Given this list of marker genes Hoxd8, E2f3, Notch1, Zfp715, Smad3, Atf6, Men1 (multiple endocrine neoplasia 1), Esr1, Sox1, Tlx2, Gfi1b, Meis1, Nfix, Meox2, Zfp982, Gcm1, Mesp1, Klf1, Batf, Irf2, Zfp131, Myb, Rhox5, Pou4f1, Irx4, Cdx4, Egr3, Onecut1, Six3, Cdc5lrt10, Pdx1, Mga, Foxo4, Tcf3, Lmx1b, Hoxa13, Hoxd13, Fosb, Cdc5lrt5, Neurog3, Glis1, Myt1l, Srebf1, Sox9, Atf1, Foxk2, E2f4, Myc, Gabpa, Dmtf1, Yy2 (NCBI Gene Id 100073351), Nkx2-6, Gsx1, Sohlh1, Tfdp1, Pou1f1, Cdc5lrt6, Cdc5lrt1, Mef2d, Mafg, Isl1, Stat5a, Sox30 (NCBI Gene Id 278440), Creb3l4, Nfat5, Brca1, Zfp175, Onecut3, Stat3, Pou5f1, Sox14, Rhox6, Ebf3, Nr2e1, Smad2, Ets1, Zic2, Ascl2, Pou4f2, Tbx20, Nfib, Zfp384, Dlx5, Tfeb, Sry, Cebpe, Mlxipl, Bmyc, Nr1h2, Scx (NCBI Gene Id 20289), Mecom, Elf3, Hoxb9, Jun, Ppara, Nfe2l1, Nkx2-5, Ebf1, Neurod6, Nfatc1, Rhox4f, Zscan21, Dmrt1, Mef2b, Lmx1a, Sohlh2, Nkx6-3, Nfatc2, Irx6 (Iroquois homeobox 6), Hsf2, Prrx2, Sox18, Bhlha15, Tbx3, Meox1, Sox2, Atf5, Esrrb, Lhx4, Nr2e3, Spic, Sox15, Zfp580, Meis2, Zfp758, Atmin, Carf, Rfx2, Pax9, Hnf4g, Hoxc4, Myf6, Grhl2, Cdc5lrt9, Ncoa3, Lhx2, Hoxa7, Klf7, Hivep2, Stat4, Plag1, Creb3, Rxrb, Six5, Rfx5, Rhox7a, Lef1, Tfcp2 (transcription factor CP2), Otx2, Msx1, Pax6, Atf2, Nrf1, Zfp819, Notch2, Sox10, Creb5, Klf4, Fev, Nhlh1, Rbpj, Csrnp2, Tfec, Hoxb2, Arnt2, Tfap2d, Nrl, Jund, E2f1, Mkx, Ar, Foxd2, Irf3, Nr3c1, Crebrf, Rhox4b, Nfyc, Rhox2f, Elf4, Mybl1, Tfap2e, Cdc5lrt7, Sox7 (NCBI Gene Id 20680), Usf1, Rhox9, Ascl5, Foxj1, Zfp639, Klf15, Grhl3 (NCBI Gene Id 230824), Rhox3g, Zfp750, Sp1, Pou3f2 (NCBI Gene Id 77364), Foxf1, Cebpg, Hsf5, Rhox4c, Zfp143, Sox3, Rhox3c, Pgr, Foxa1, Neurod1, Yy1, Mef2a, Gzf1, Fosl1, Dlx3, Nkx2-1 (NCBI Gene Id 21869), Zscan2, Usf3, Nr4a3, Figla, Mef2c, Klf6, E4f1, Nr1i3, Grhl1 (grainyhead like transcription factor 1), Rbpjl, Rhox3a, Barhl2, Rorb, Zfat, Usf2, Hhex, Foxi1, Fos, Zfp930, Foxc1, Rhox4a, Mzf1, Zfp677, Irf5, Tfap4, Foxd1, Dlx2, Irf6 (NCBI Gene Id 98477), Trp53, Mesp2, Hoxb1, Egr4, Ptf1a, Barhl1, Gm14434, Cebpd, Rhox4g, Hoxb7, Tfcp2l1, Sp7, Rel, Myod1, Tfap2c, Phox2b, Hoxa9, Tead4, Cdc5lrt4, Tcf12, Mybl2, Sox11, Creb1, Ebf2, Elf1, Erg (ETS transcription factor), Tcf15, Rhox2h, Mtf1, Fezf2, Litaf, Gli2, Hnf1a, Hif1a, Zeb2, Nr1i2, Crx, Foxo3, Hoxb5, Nkrf, Plagl2 (NCBI Gene Id 99408), Foxj3, Junb, Tbx21, Zfp292, Fosl2, Atoh1, Foxa2, Dbp, Pparg, Rhox2c, Pitx1, Meis3 (Meis homeobox 3), Gata2, Irx3 (Iroquois related homeobox 3), Pax8, Foxc2, Spib, Hoxd3, Foxf2 (forkhead box F2), Zbed4, Plscr2, Tfap2a, Tcf7l2, Rfx4, Nobox, Nkx2-9, Pax1, Elk4, Nr6a1, Zfp341, Gata4 (NCBI Gene Id 14463), Klf13, Mitf, Rhox1, Mafa, Smad1, Prdm2, Hoxb3, Hoxa1, Lhx3, Nr1h3, Myf5, Fli1, Rhox4e, Ebf4, Cdkn2a (NCBI Gene Id 18560), Etv2, Arx, Stat5b, Glis3, Foxp3, Irf4, Hlf, Csrnp1, Zbtb17, Smad4, Nfya, Cebpa, Prdm16, Twist1, Dmrt2, Sox21, Ddit3, Hoxc10, Rfxank, Cdc5l, Nfatc3, Notch4, Pitx2 (NCBI Gene Id 338526), Alx4, Hsf1, Tfap2b, Onecut2, Irf1, Zic3, Rhox3f, Myt1, Nanog, Nr5a2, Phox2a, Elf5, Osr2, Rfx6, Glis2, Heyl, Mafb, Etv4, Rhox2g, Bsx, Etv1, Nhlh2, Ikzf3, Ubp1, Nr4a1, Srf, Nr1h4, Plscr1, Spi1, Rhox8, Pitx3, Nfkb1, Pbx3, Klf9, Rhox7b, Atf1-ps, Egr2, Maff, Zfp395, Barx2 (BarH-like homeobox 2), Nfic, Clock, Zfp42, Prop1, Nfia, Gmeb2, Zfp523, Hoxa10 (homeobox A10), Sall2, Etv6, Etv5, Elk3, Hoxc13, Zic1, Neurod2, Creb3l2, Six1, Alx1, Kmt2d (lysine (K)-specific methyltransferase 2D), Rela, Zfx, Zfp24 (zinc finger protein 24), Bnc1, Creb3l3, Gbx2, Hnf4a, Plagl1, E2f5, Esrra, E2f2, Zfp113, Runx2, Satb2, Ovol2, Rhox2d, Atf4, Hoxa5, Pbx2, Wt1, Hinfp, Nr4a2, Foxl2, Cdc5lrt8, Elk1, Esrrg, Hoxd4, Nfe2l2, Klf10, Trp63, Zfa-ps, Nfkb2, Atf6b, Tbx1, Cebpb, Stat6, Casz1, Tcf21, Pou4f3, Tef, Klf5, Foxh1, Vezf1, Foxr1, Gcm2, Thap11, Tbx5, Trp73, Ctcfl, Cdx1, Six2, Sox12 (SRY (sex determining region Y)-box 12), Gata1, Rhox2b, Rhox3h, Epas1, Hoxd10, Rfxap, Npas4, Mlxip, Mycn, Otx1, Rhox4d, Gtf2i, Esr2, Zbtb7b, Hoxc11, Hand2, Atf3, Sox17, Nkx2-2, Tbr1, Maf, Hand1, Creb3l1, Pbx1 (pre B cell leukemia homeobox 1), Tfdp2, Bcl11b (NCBI Gene Id 78682), Ehf, Foxn1, Prdm4, Pou2f3, Tcf4, Zfp358, Tbx19, Nr2c2, Foxj2, Bach1, Runx1, Nfyb, Msgn1, Pax5, Foxo1, Gata3, Mixl1, Gmeb1, Bmal1, Pou2f2, Rhox2a (NCBI Gene Id 75199), Mycs, Prrx1, Zfp628, Rax, Egr1, Csrnp3, Six4, P2rx2, Rreb1, Zfp212, Myog, Sox4, here is a description of the gene set: studied in species Mus musculus A DNA-binding transcription factor activity that activates or increases transcription of specific gene sets. Mouse Gene Set: GOMF_DNA_BINDING_TRANSCRIPTION_ACTIVATOR_ACTIVITY